The following is a description of a gene set: species: Mus musculus electronically inferred by orthology from the curated human pathway This event has been computationally inferred from an event that has been demonstrated in another species.<p>The inference is based on the homology mapping from PANTHER. Briefly, reactions for which all involved PhysicalEntities (in input, output and catalyst) have a mapped orthologue/paralogue (for complexes at least 75% of components must have a mapping) are inferred to the other species. Reactome Pathway: Mismatch repair (MMR) directed by MSH2:MSH3 (MutSbeta) part of: Mismatch Repair, and this is the list of marker genes: Lig1, Pold1, Pold2, Pold4, Msh2, Msh3, Rpa1